The following is a description of a gene set: species: Mus musculus from publication Chen Y, Wang X (PMID 31504780) Mouse Gene Set: MIR_7060_3P Genes predicted to be targets of miRBase v22 microRNA mmu_miR_7060_3p in miRDB v6.0 with MirTarget v4 prediction scores > 80 (high confidence targets)., and this is the list of marker genes: Otud1, Blmh, Chtf8, Ro60, Ppm1e, Mier3, Dcaf10, Nanp, Patj, Me1, Lrrc8d, Rasgef1b, Hip1, Slc7a11, Ccdc14, Ubfd1, Epc1, Sspn, Pcdh15, Zcchc2, Lcp1, Gpc5, Ctdspl2, Cfap68, Ccnc, Cdnf, Lrrn3 (NCBI Gene Id 16981), Ell2, Prps1l3, Gabrg1, Phf6, Zfp870, Cdh8, Thap1, Dnajc5b, Nup62cl, Csn1s1, Ptpro, Serpina5, Plxna1, Stk17b, Unc5c (unc-5 netrin receptor C), Slc38a6, Mical2, Greb1, Pogk, Klhl34, Ugt8a, Necab1, Slc9a1